Given this list of marker genes UBE2QL1, CIB3, SLC35D1, MAPK1, NAA40, LRRC59, MYBL1, CDCA7, CCDC25, PKIG, RPRD1B, KAT7, UGCG, RORC, PAPSS2, GPR34, SMARCB1, BCL2L1, LCA5, CDC34, MYB, ANO6, GRIP1, HDX, ITPRID1, ACTL9, HDAC2, SLC37A2, CYFIP2, CECR2, GSTCD (glutathione S-transferase C-terminal domain containing), ANXA2, SPATS2L, MTBP, RFX5, TAP2, ADGRE1, USP7, CRIP1, PTGIR, PPEF1, CTNND2, CD2BP2, PTP4A3, GTF2F1, LGALS7, CD6, LIG4, SOCS1, PTPN7, CARF, RBM15B, F13A1, RAI1, PYCR2, CPT2, ANGPT1 (NCBI Gene Id 284), CSRNP1, PRELID3B, MIR592, EIF3A, ZFAND4, TIFA, NUP155, URB2, SNORA36B, CTBP1, MLXIPL, AARSD1, MEF2A (myocyte enhancer factor 2A, NCBI Gene Id 4205), CSTF2, EAF1, SF1, NCBP1, CNOT9, COQ7, PSAP, FBXO15, H3C7, ATP5PO, WWC2, MATN2, ALG10B, DAB2IP, CERK, ICAM2, ARL5C, KCNA1, TMEM25, FBXO48, SCYL1, FOXI1, CD5, NTN1, NFKBIE, ATP6V1C2, MYO10, ZEB1, EGLN3, TOB2, MYO1C, PLXND1, COX20, AGFG2, MED14 (mediator complex subunit 14), ARL6 (NCBI Gene Id 84100), IL21, LMNB2 (lamin B2), PPP5C, SEC24B, PAIP1, RBBP8, CSNK2B, XIRP2, SENP1, CNTROB, RFC5, ZDHHC14, MARS1, SEC23IP, SLC12A4, HIRA, TSC22D1, FGFBP1, ATP13A3, PHGDH, PPP1R14B, ANGPTL2, RGS12, FLNB, SF3A1, FAM117A, MAP3K1, RAPGEF3, PCNX2, RTKN2, SEMA7A, PPP1R16B, PRAM1, HAUS5, CDK2AP1, ATP1B1, PTPRF, PSME4, MIR542, PTPRJ, GEM, SLC16A1, ITPR1 (NCBI Gene Id 619543), RPIA, LANCL2, SLC38A1, SLC25A25, ELAVL1, STAU1, CAMKV, RNF157, CSNK1E, RASGEF1B, EMCN, B3GNT5, NSG2, CTNNA3, PPT2, FBXL19, AGBL5, here is a description of the gene set: from publication Olex AL, Hiltbold EM, Leng X, Fetrow JS (PMID 20682054) BACKGROUND: Dendritic cells (DC) play a central role in primary immune responses and become potent stimulators of the adaptive immune response after undergoing the critical process of maturation. Understanding the dynamics of DC maturation would provide key insights into this important process. Time course microarray experiments can provide unique insights into DC maturation dynamics. Replicate experiments are necessary to address the issues of experimental and biological variability. Statistical methods and averaging are often used to identify significant signals. Here a novel strategy for filtering of replicate time course microarray data, which identifies consistent signals between the replicates, is presented and applied to a DC time course microarray experiment. RESULTS: The temporal dynamics of DC maturation were studied by stimulating DC with poly(I:C) and following gene expression at 5 time points from 1 to 24 hours. The novel filtering strategy uses standard statistical and fold change techniques, along with the consistency of replicate temporal profiles, to identify those differentially expressed genes that were consistent in two biological replicate experiments. To address the issue of cluster reproducibility a consensus clustering method, which identifies clusters of genes whose expression varies consistently between replicates, was also developed and applied. Analysis of the resulting clusters revealed many known and novel characteristics of DC maturation, such as the up-regulation of specific immune response pathways. Intriguingly, more genes were down-regulated than up-regulated. Results identify a more comprehensive program of down-regulation, including many genes involved in protein synthesis, metabolism, and housekeeping needed for maintenance of cellular integrity and metabolism. CONCLUSIONS: The new filtering strategy emphasizes the importance of consistent and reproducible results when analyzing microarray data and utilizes consistency between replicate experiments as a criterion in both feature selection and clustering, without averaging or otherwise combining replicate data. Observation of a significant down-regulation program during DC maturation indicates that DC are preparing for cell death and provides a path to better understand the process. This new filtering strategy can be adapted for use in analyzing other large-scale time course data sets with replicates. Genes up-regulated in bone marrow-derived dendritic cellstreated by poly(IC): 3h versus 12h. studied in species Homo sapiens Human Gene Set: GSE21033_3H_VS_12H_POLYIC_STIM_DC_UP